Given this list of marker genes HLA-DMA, GAB2 (GRB2 associated binding protein 2), SHMT2, DAP3, CIITA, RPL15, FCER2, IGHA1, LY96, C3orf52, MIEF1, PABPC3, SSBP2, EPB41L2, TTC9, CD72, BACE2, LTA4H, TSEN2 (tRNA splicing endonuclease subunit 2), ASMTL, ELOA-AS1, EPS8L2, NSD3 (nuclear receptor binding SET domain protein 3), SQLE, BLCAP, HESX1, PPP1R16B, COL9A3, RUBCNL, REPS2, EHD3, PPM1E, CLIC4, BCL6, ADPRM, DSE, HK2, CCT2 (chaperonin containing TCP1 subunit 2), TOR3A, NSUN5, CBR3, APTX, PPA1, TJAP1, GUCY2C, CIRBP, IRF8, ADO, ZDHHC14, CCDC6, MYH3, JADE3, TBC1D22A, MX1, CR1, EBI3 (Epstein-Barr virus induced 3), OR7E47P, HDAC3, SLAMF1, FDFT1, FCGR2B, NUDT2, ATP6V1G1, BIK, PKIG, LAMC1, ANXA13 (NCBI Gene Id 312), DNAJC3, OAZ3, GABARAPL2, PTPRK, LYRM4, SCN3A, BCL11A, TRADD (NCBI Gene Id 8717), GATM, GFOD2, CD19, RPL24, EIF3L, B9D2, RPAIN, PDLIM1, FA2H, CRIP1, TMEM243, ITM2C, CRYM, GTF2F2, HLA-DRB4, LTB, H4C9, TCL1A, ISG20L2, P2RY10, MRPS27, IRGQ, ATP8B3, UTP3, RAB3GAP1, GLDC, H2BC12, FBXO41, SERGEF, IMPG2, HLA-DMB, HDAC9, SMPD2, HS3ST1, NAXD, LAPTM4A, ADARB1, TSPAN3, LDHB, RPL10A, H2AC6, MZB1, FAM30A, RHOH, GTF2A1, RAD23B (NCBI Gene Id 5887), CACNA1A, NSDHL, ARPC3, GNA12, MTCL1, RASGRP3, UBE2N, OPN3 (NCBI Gene Id 23596), SAV1, TNFRSF13B, ASXL1, LYL1, TNS3, PIP5K1B, FCRL2, ZCWPW1, THADA, PRODH, HMBS, HLA-DOB, HSBP1 (NCBI Gene Id 3281), UVRAG, BAIAP3, UBE2J1, TCF3, CD200, HEMK1, PPP6C, NFATC1, IRF4, P2RX5, EZR, ALOX5, MARCHF3 (membrane associated ring-CH-type finger 3), ISG20, FH, AMPD3, HPS5, G3BP1 (NCBI Gene Id 10146), PSMA2, ENPP3, PABPC4, PNOC, ATP5F1A, WDR77, CLNS1A, LARP1, ADK, GPRC5C, SPATS2, ABCB9, NDUFAF1, SWAP70, CNTNAP2, BANK1, PDE4B, MARCKS, PDE6B, DMAC2L, PUS1, N6AMT1, OSBPL10, GNB5, KIAA0319, AQP3, TRIM25, NT5E, CBFA2T2, B4GALT7, HLA-DPB1, SEL1L3, TMEM156, TSHR, PTCD1, CLDN7, TRAF3, here is a description of the gene set: studied in species Homo sapiens In the present study we used Affymetrix oligonucleotide microarrays to produce gene transcription profiles for the major leukocyte types in humans. This comprehensive dataset enabled us to not only establish which genes were expressed in each leukocyte type, but also which genes were expressed in each subset after activation. The used of a comprehensive dataset of gene profiles from all the major human leukocyte subsets enabled a novel and powerful means for identification of genes associated with single leukocyte subsets, or different immune paradigms. Human Gene Set: GSE3982_BCELL_VS_NKCELL_UP from publication Jeffrey KL, Brummer T, Rolph MS, Liu SM, Callejas NA, Grumont RJ, Gillieron C, Mackay F, Grey S, Camps M, Rommel C, Gerondakis SD, Mackay CR (PMID 16474395) Genes up-regulated in comparison of B cells versus NK cells.